Given this list of marker genes IL4R, EVI5, ESD, JAK1, CD83, SGPL1, SLC5A6, GPR137B, ATF6, ZC3H14, UNC119, LSM6, ARID5A, H2BC15, IMPDH2, ADA, STAT4, ANAPC5, NCOA4, SEMA3C, RPLP1, UBE2E3, ATG14, DPF2, TNFAIP6 (NCBI Gene Id 7130), UBXN2B, TBCC, ITGA6, CEP57, IL12B, HOXB1, CCDC6, ANKRD46, AHCY, ERP44, ZNF200, ST6GAL1, TCF7L2, PSMD4, PANX1, SNX19, PIGF, GLCE, MYH9, MR1, DLC1, STX6 (syntaxin 6), PDE6D, H4C13, CLNS1A, SLC4A2, SSB, SLC35A1, H2BC21, OXA1L, OVOL2, HLA-E, LAMP3, MTRR, LYN, ENC1, N4BP2L2, DNAJC16, TNFAIP3, ST8SIA4, ZNF175, ALCAM, CYP2C19, POLR2J, WDR7, NDUFV2, MRFAP1L1, DELE1, CDS1, ZNF35, SPG7, SH3BGR, H2BC7, MANBA, CCS (NCBI Gene Id 9973), STX7, CS, PEX13, PKD2, KDM1A, ITPRID2, H2BC10, DYNLT3, CYRIA, MT1A, RPS8, H2BC14, UBXN1, UBE2D1, RAP1GAP, ENG, RYK, ETV5, SLC25A11, MDM1, NLRP3, H2BC5, ARF3, CLK2, AASDHPPT, PDHB (NCBI Gene Id 5162), PTPN2, HADHA, ALDH9A1, TBPL1, PPP3CB, EXT2, MAP3K5, TRAF3IP2, NAP1L1 (NCBI Gene Id 64165), TRAF4, RECQL, LRPPRC, ZNF330, AMD1, NUP42, NSA2, DHX16, RPS2, FH, ING3, SOCS1, RPLP0 (NCBI Gene Id 6175), FNBP1, H2BC12, AKAP11, GLO1, SPRY1, MARCKSL1, MT2A (metallothionein 2A), SRPK1, KLHDC3, ACSL4, H2BC4 (H2B clustered histone 4), GSTA2, TXNL4A, PLOD1, RPL17, UBE3C, RAB3GAP1, TEX261, EEF1D, DPYD, ZSCAN26, TUBB, CDK14, RPS15A, DGCR5, RNF19B, RAB31, PATZ1, PABPC1, CAMTA2, ZNF518A, PTPRJ, DDX52, NCAPD2, SUPT4H1, LMO2, TOR1B, H2BC13, POLB, DHX29, H2BC6, TREX1, SLC35A2, NIPSNAP2, SERPINB1, EHD1, ATP5F1C, ZNF212, EEF2, CDIPT, PHB2, COL4A1, KIF3B, HERC3, ERCC6, IGBP1, ACAA1, ATP5F1A, ZNF10, MICA, FLT1, FRAT2, CRYBG3, PRKAA1, NSF, RFTN1, COQ2, EVI2B (NCBI Gene Id 2124), SLC5A5, PTDSS1, RACK1, here is a description of the gene set: Human Gene Set: GSE43260_BTLA_POS_VS_NEG_INTRATUMORAL_CD8_TCELL_DN from publication Haymaker CL, Wu RC, Ritthipichai K, Bernatchez C, Forget MA, Chen JQ, Liu H, Wang E, Marincola F, Hwu P, Radvanyi LG (PMID 26405566) Genes down-regulated in tumor-infiltrating CD8 T cells: BTLA+ versus BTLA-. studied in species Homo sapiens Adoptive T-cell Therapy (ACT) involves using tumor-infiltrating lymphocytes (TIL) isolated from metastatic melanoma and expanding them ex vivo prior to infusion into lympho-depleted patients. This is one of the most promising approaches to treat metastatic melanoma, with the rates of clinical response between 48-50% based on studies done at NCI, M.D. Anderson Cancer Center (Houston, TX), and Sheba Medical Center (Tel Aviv, Israel). In the Phase II ACT Trial at M.D. Anderson Cancer Center, our group has uncovered an association between positive clinical response and the amount of CD8+ tumor-infiltrating lymphocytes expressing B and T Lymphocyte Attenuator (BTLA), a reported inhibitory receptor on T-cells. We used microarrays to detail the differences in the global programme of gene expression between CD8+BTLA+ vs CD8+BTLA- TILs in order to understand the molecular basis of the clinical association.